Given this list of marker genes GIT1, PRSS54, ELOVL6, MFGE8, CXXC5, NF2 (NCBI Gene Id 654093), PDPK1, RRAS2, PTBP3, MBNL3, MFSD14A, MFAP5, BSPH1, WDTC1, ANKRD61, SH3PXD2B, SGCD, CCDC126, TUSC2, CREBL2, IRF5, CRTAP, CNTN1, TRIM10, PREX2 (NCBI Gene Id 80243), ACVR2A, NOVA1, ADAMTS15, RIPK4, ROCK2, ENTPD1, ATG5, PHF8, SEMA3D, SYTL4, DENND5A, HMGB1, DGKH, MYCBP2, SRI, JAG1, ELK4, BNC2, OVOL1, CCDC103, HECTD1, here is a description of the gene set: Human Gene Set: MIR6858_3P species: Homo sapiens from publication Chen Y, Wang X (PMID 31504780) Genes predicted to be targets of miRBase v22 microRNA hsa-miR-6858-3p in miRDB v6.0 with MirTarget v4 prediction scores > 80 (high confidence targets).